Given this list of marker genes Slc16a7, Acacb, Slc16a3 (solute carrier family 16 (monocarboxylic acid transporters), member 3), Emb, Slc16a1, Myc, here is a description of the gene set: Mouse Gene Set: GOBP_PLASMA_MEMBRANE_LACTATE_TRANSPORT The directed movement of lactate across a plasma membrane. species: Mus musculus